Given this list of marker genes GYG2, GYS2, here is a description of the gene set: Reactome Pathway: Glycogen storage disease type 0 (liver GYS2) part of: Glycogen storage diseases Glycogen synthase 2 (GYS2 "liver") normally catalyzes the addition of glucose residues to a growing glycogen molecule. In its absence, glycogen synthesis fails. Expression of GYS2 is confined to the liver and its deficiency is most prominently associated with fasting hypoglycemia. studied in species Homo sapiens